Given this list of marker genes Bub1, Ppp2r1b, Ppp2r1a, Meikin, Bub1b, Sgo2a, here is a description of the gene set: species: Mus musculus The cell cycle process in which centromeres of sister chromatids are joined during meiosis. Mouse Gene Set: GOBP_MEIOTIC_SISTER_CHROMATID_COHESION_CENTROMERIC